Given this list of marker genes POLR1B, MID1, DACT1, KDM6A (lysine demethylase 6A), HPS6, CD3G (NCBI Gene Id 917), MKKS, LFNG, DDB1, MESP2, POLR1C, RNU12, RECQL4, DLL3, DYNC2I2, DOCK2, FREM1, TGFB1, DYNC2I1, TCOF1, MNX1, PKP1, ITGA8, GREB1L, SLC35A2 (NCBI Gene Id 7355), IL10RB, UBR1, CDK8, SALL4, TCTN3 (tectonic family member 3), HES7, DYNC2H1, SPINT2, GFRA1, CAPN15, KIF7, SYK, WNT9B, KMT2D, SALL1, PI4KA, PIGN, ELF4, LONP1, NCF4, POR, WDR35, RIPPLY2, FGF20, JAK3, RET, OCRL, CCNQ, IFT80, POLR1D, here is a description of the gene set: Urogenital fistula The presence of a fistula affecting the genitourinary system. Human Gene Set: HP_UROGENITAL_FISTULA studied in species Homo sapiens